Given this list of marker genes Per1, Kank2, Strn3, Dab2, Gh, Vps11, Ufm1, Ddx5, Hdac1, Pten, Wbp2, Calr, Srarp (steroid receptor associated and regulated protein), Foxa1, Ddrgk1, Cnot1, Fshr, Esr2, Cnot9, Bmal1, Phb2 (NCBI Gene Id 12034), Usp26, Bdnf, Trim68 (NCBI Gene Id 244173), Zfp366, Ufsp2, Sfrp1, Cnot3, Lbh, Kdm5d, Pias2, Ncoa3, Src, Igf1, Ar, Foxp1, Lats1, Heyl, Isl1, Park7, Nodal, Foxh1, Uba5 (NCBI Gene Id 66663), Crebrf, Ncoa2, Ntrk2, Phb1, Akap13 (NCBI Gene Id 76109), Ncor1, Safb2, Hmga2, Prmt2, Parp1, Rnf14, Brca1, Carm1, Nr0b1, Ppp5c, Zbtb7a, Pagr1a, Trp63, Shq1, Vps18, Skp2, Rhoa, Ufl1, Safb, Lmo3, Med1, Ghrhr, Tcf21 (NCBI Gene Id 21412), Smarca4, Cyp7b1, Cry1, Ep300, Sirt1, Nr3c1, Cnot2, Ncor2, Cry2, Rnf6 (NCBI Gene Id 74132), Kmt2d, Pak1, Dnaaf4, Clock, here is a description of the gene set: species: Mus musculus Any process that modulates the frequency, rate or extent of the activity of any intracellular steroid hormone receptor signaling pathway. Mouse Gene Set: GOBP_REGULATION_OF_INTRACELLULAR_STEROID_HORMONE_RECEPTOR_SIGNALING_PATHWAY